The following is a description of a gene set: Reactome Pathway: Formation of RNA Pol II elongation complex studied in species Homo sapiens part of: RNA Polymerase II Transcription Elongation TFIIS is a transcription factor involved in different phases of transcription, occurring in a major ubiquitous form and other tissue specific forms. TFIIS stimulates RNA Pol II complex out of elongation arrest. <BR> Other transcription factors like ELL, Elongin family members and TFIIF interact directly with elongating Pol II and increase its elongation rate. These factors have been observed to act on naked DNA templates by suppressing transient pausing by the enzyme at all or most steps of nucleotide addition. In Drosophila, ELL is found at a large number of transcriptionally active sites on polytene chromosomes. In general, ELL is suspected to have more unidentified functions.<BR> Elongin is a heterotrimeric protein complex that stimulates the overall rate of elongation. In addition, Elongin may act as an E3 Ubiquitin ligase. Ubiquitylation of RNA Pol II occurs rapidly after genotoxic assault by UV light or chemicals, and results in degradation by proteasome. The FACT complex appears to promote elongation by facilitating passage of polymerase through chromatin.<BR> All these factors contribute to the formation of a processive elongation complex centered around the RNA Pol II complex positioned on the DNA:RNA hybrid. This enables the RNA Pol II elongation complex to function as a platform that coordinates mRNA processing and export (Reviewed by Shilatifard et al., 2003)., and this is the list of marker genes: CCNK, GTF2H3, IWS1, CTDP1, POLR2J, CDC73, SSRP1, ELL, GTF2F2, EAF2, POLR2A, CCNH, ELOA2, NELFCD (NCBI Gene Id 51497), GTF2H4, NELFE, POLR2B, SUPT5H, ERCC3, POLR2F, ELOC, ELOB, POLR2I (NCBI Gene Id 5438), CCNT1, SUPT6H, POLR2K, CCNT2, CDK7, POLR2L, GTF2H2, RTF1, ELOA, GTF2H1, TCEA1, EAF1, MLLT1, SUPT16H, POLR2E, MLLT3, PAF1, POLR2D, LEO1, POLR2H, GTF2F1, GTF2H5, CDK9, AFF4, NELFA, SKIC8, MNAT1, NELFB, NCBP1, ERCC2, POLR2C, POLR2G, SUPT4H1, NCBP2, CTR9